The following is a description of a gene set: Up-regulated genes defining rejection of mammary carcinoma (MMC) tumors. from publication Worschech A, Kmieciak M, Knutson KL, Bear HD, Szalay AA, Wang E, Marincola FM, Manjili MH (PMID 18381452) Human Gene Set: WORSCHECH_TUMOR_REJECTION_UP We have previously shown T-cell-mediated rejection of the neu-overexpressing mammary carcinoma cells (MMC) in wild-type FVB mice. However, following rejection of primary tumors, a fraction of animals experienced a recurrence of a neu antigen-negative variant (ANV) of MMC (tumor evasion model) after a long latency period. In the present study, we determined that T cells derived from wild-type FVB mice can specifically recognize MMC by secreting IFN-gamma and can induce apoptosis of MMC in vitro. Neu transgenic (FVBN202) mice develop spontaneous tumors and cannot reject it (tumor tolerance model). To dissect the mechanisms associated with rejection or tolerance of MMC tumors, we compared transcriptional patterns within the tumor microenvironment of MMC undergoing rejection with those that resisted it either because of tumor evasion/antigen loss recurrence (ANV tumors) or because of intrinsic tolerance mechanisms displayed by the transgenic mice. Gene profiling confirmed that immune rejection is primarily mediated through activation of IFN-stimulated genes and T-cell effector mechanisms. The tumor evasion model showed combined activation of Th1 and Th2 with a deviation toward Th2 and humoral immune responses that failed to achieve rejection likely because of lack of target antigen. Interestingly, the tumor tolerance model instead displayed immune suppression pathways through activation of regulatory mechanisms that included in particular the overexpression of interleukin-10 (IL-10), IL-10 receptor, and suppressor of cytokine signaling (SOCS)-1 and SOCS-3. These data provide a road map for the identification of novel biomarkers of immune responsiveness in clinical trials. species: Mus musculus, and this is the list of marker genes: NFAT5, TLR6, CXCL11, CCL4, CCL5 (C-C motif chemokine ligand 5), IL17F, LCK (NCBI Gene Id 95387), IL4I1, MSR1, CCL15, IFNG, STAT2, IFITM1, NKRF, TLX1, IL5, TCL1B, IL1A, IL31, CCL23, CXCL2, EBF4, TLR4, IFIT1B, IL36G, JCHAIN, IL2RG, IL23R, TNFRSF4, CCR10, NKIRAS2, TAGAP, IL7 (interleukin 7), KLRD1, CLEC10A, IL7R, ACKR1, TNFRSF1B, IGLV2-18, GZMB, ITK, IL17RB, NFKBIZ, STAT6, IL1B, IRF4, CCL22, IFI27, CCL8, IFNA13, CCL11, ALCAM, TNFSF11, CCL1, CCRL2, BCL2A1, IL1RAP (NCBI Gene Id 3556), IRF6, PYHIN1, CKLF, FASLG